The following is a description of a gene set: Ovarian tumor domain proteases Human Gene Set: REACTOME_OVARIAN_TUMOR_DOMAIN_PROTEASES species: Homo sapiens, and this is the list of marker genes: UBC, RIPK2, UBA52, OTUB1, TRIM25, NOD2, YOD1 (NCBI Gene Id 55432), TNIP2, TRIM4, TP53, VCPIP1, VCP, MAVS, TRAF6, ESR1, IFIH1, ZRANB1, IKBKG, CDK1, UBE2D1 (ubiquitin conjugating enzyme E2 D1), OTUD7B, OTUB2, TNIP1, PTEN, APC, RNF135, RPS27A, NOD1, OTUD7A, OTUD3, RIPK1, RIGI, UBB, TNFAIP3, TNIP3, RHOA, RNF128, TRAF3, OTUD5